The following is a description of a gene set: studied in species Homo sapiens mGluR5-Ca2+ -apoptotic pathway. Pathway ID: N00984. Pathway type: Reference. Pathway class: nt06528 Calcium signaling. Human Gene Set: KEGG_MEDICUS_REFERENCE_MGLUR5_CA2_APOPTOTIC_PATHWAY Pathway Definition from KEGG: Glutamate -> GRM5 -> GNAQ -> PLCB -> IP3 -> ITPR -> Ca2+ -- MCU -> Ca2+(mito) -- MPTP -> CYCS == APAF1 -> CASP9 -> (CASP3,CASP7), and this is the list of marker genes: SLC25A31, CASP3, SLC25A4, GRM5, ITPR3, VDAC3, PLCB3, VDAC1, PLCB1, SLC25A6, PLCB4, CYCS, ITPR2, PLCB2, VDAC2, CASP7, MCU, GNAQ, CASP9, ITPR1, SLC25A5, APAF1